The following is a description of a gene set: studied in species Homo sapiens Human Gene Set: MODULE_379 Genes in the cancer module 379., and this is the list of marker genes: ACSL6, RBMXL2, KRT32, NECTIN1, SHBG, IVL, HTR4, GALNS, SERPINA4, BMP10, ALDOB, GIP, CCDC9, ABCC8, PIGL, PI3, MYOZ3, MAGI1, AMELX, AMMECR1 (AMMECR nuclear protein 1), ATOSB, CLDN5, EXOSC2, PGC, LYPD3, TNFRSF13B, TRIM10, NR2E3, FAM131B, SCN2B, IKBKG, RIMS2, PTPRN, TEX28, CYP27B1, UNC119B, TFAP2B, ASIC3, MPZL2 (myelin protein zero like 2, NCBI Gene Id 95160), AKAP7, SLC7A4, PRF1, NELFA, STATH, MAGEC1, P2RX1, HMHB1, ABCB9, MET, NR0B2, S1PR2, ODF1, AQP8, ABCA1, HSD17B1, GRIK5, JAKMIP1, SCGN, KCNN1, GREM1, ALOX15, EIF1AY, CCKAR, CEACAM3, GFPT2, SYT5, SIX3, TAGLN3, CEP135, BRD4, SIX6, KIF21B, MSI1, LCE2B, NRG2, CTSG, PTH2R, PPP4R2, ADGRL3, CNTN6, CHP2, MACIR, ACTL6B, ASIP, NDRG2, NRXN1, AANAT, AKAP3, HOXC11, DKK4, HCRT, TACC2, CHST1, CLDN9, SLIT3, S1PR4, SEZ6L, LRIT1 (leucine rich repeat, Ig-like and transmembrane domains 1), TAOK2, KCND3, TNFRSF21, TBXT, FLT1 (fms related receptor tyrosine kinase 1), PSCA, MTHFR, MAGEA9, H3C6, CDH1, ARFGAP3, EXD2, DNAJB12, PGAM2, APC2, GRM2, H6PD, TNFRSF6B, TNFRSF10C, GRK1, SOX10, PRELID3A, CRCP, RGS9, MYCL, GALR3, TRIB1, MAGEA4, SLC22A6, FCN2, L1CAM, ATP4A, UCN, GNG7, EIF4EBP1, ING1, CDK5R2, GNMT, SLC7A11, HOXB1, KCNQ3, PIK3IP1, GPR3, FKBP6, SPINK2 (serine peptidase inhibitor Kazal type 2), SCAMP5, LEFTY1, NEMF, NAT8, NSG1, MTA2, ZBTB24, SSTR2, PKP3, REN, PRB4, PAX7, CCK, INHBC, SIT1, RAC3, SSX4, TRPM2, ADAM20, SRPK3, SLC17A3, VAMP1, CLDN14, RUNDC3A, FAM13A, ENTPD2, MLLT1, TP63, HBB, RECQL5, SEMA7A, KCTD17, GAGE12G, TBX1, EMID1, SLC17A7, PTP4A3, NNAT, REG1B, CHST3, PIGO, TRIM15, RIBC2, CYP2C19, ATP6V1G2, PLIN1, GLE1 (NCBI Gene Id 8012), PZP, POM121L9P, NTRK1, REPS2, B3GNT3, SPC25 (NCBI Gene Id 57405), ECE2, ZNF143, SLC22A18AS, KIAA0586, NTNG1, LORICRIN, CCL7, GAS8